Given this list of marker genes Nbn, Polq, Topbp1, Plk1, Rhno1, Hmces (NCBI Gene Id 97315), Helq, Lig3, here is a description of the gene set: An instance of double-strand break repair via nonhomologous end joining that is independent of factors important for V(D)J recombination (as opposed to classical nonhomologous end joining). It often results in a deletion with microhomology (i.e. 5-25bp homology) at the repair junction. Among different subclasses of nonhomologous end joining (NHEJ), alternative NHEJ appears to play a significant role in the etiology of mutations that arise during cancer development and treatment. Mouse Gene Set: GOBP_DOUBLE_STRAND_BREAK_REPAIR_VIA_ALTERNATIVE_NONHOMOLOGOUS_END_JOINING studied in species Mus musculus